Given this list of marker genes NPDC1, HOXA10 (homeobox A10, NCBI Gene Id 3206), RPL38, KCND2, ARTN, C3orf20, ELN, SCN3A, GPR156 (NCBI Gene Id 165829), CSMD3, WWC1, GRN, DENND2C, SERBP1, PYM1, SLCO3A1, FIS1, PTMA, PITPNM1, RPP25L, LETMD1, POU2F3, TOMM40L, SORCS2, COL11A1, MIR646HG, ADGRB2, ACBD4, CXCL12, MB, RERG, SEC31B, BCL6B, TTI1, LRP1, DAPK2, GRK5, INKA1, CHRM1, PIK3R1, KPNA6, ARL8B, MED13, PCDH12, GAS7, CNTNAP1, PCGF1, RPRD1B, EXOSC2, USH1G, SSH2, DLX2, SMAD7, PLXNA2, OPCML, ARMC12, LRCH1, CADPS, TMEM51, LINC00518, NXN, SOX10, EXT2, CA14, CORIN, ARF1 (NCBI Gene Id 375), IL6, SRCIN1, C11orf52, GPR37L1, SLIT3, YY1, CIAO1, STK32B, ESR2, UPK2, KAZALD1, CDC20B, MMP1, RPS4X, NUFIP2, CCNB1IP1, THBS3, TSC22D3, GFI1B, TYSND1, OTOP2, ZNF366, DGKA, CSF3, TMEM127 (transmembrane protein 127), C1QBP, CABP1, MTX1, FLT3LG, AQP6, RPLP0, GRPR, SOST, PUM2, SLC26A10P, NOP10, ANKS6, STAG1, ADORA1, SLC35E4, TMEM51-AS1, ARMCX6, C3orf49, MDK, RORA, FBXO16, TMEM31, FAM177B, ANKRD2, CCR10, ALK, GAD1, LINC02724 (long intergenic non-protein coding RNA 2724), VSTM2L, here is a description of the gene set: Comprehensive identification of all functional elements encoded in the human genome is a fundamental need in biomedical research. Here, we present a comparative analysis of the human, mouse, rat and dog genomes to create a systematic catalogue of common regulatory motifs in promoters and 3' untranslated regions (3' UTRs). The promoter analysis yields 174 candidate motifs, including most previously known transcription-factor binding sites and 105 new motifs. The 3'-UTR analysis yields 106 motifs likely to be involved in post-transcriptional regulation. Nearly one-half are associated with microRNAs (miRNAs), leading to the discovery of many new miRNA genes and their likely target genes. Our results suggest that previous estimates of the number of human miRNA genes were low, and that miRNAs regulate at least 20% of human genes. The overall results provide a systematic view of gene regulation in the human, which will be refined as additional mammalian genomes become available. Human Gene Set: CCANNAGRKGGC_UNKNOWN from publication Xie X, Lu J, Kulbokas EJ, Golub TR, Mootha V, Lindblad-Toh K, Lander ES, Kellis M (PMID 15735639) Genes having at least one occurrence of the highly conserved motif M45 CCANNAGRKGGC in the regions spanning 4 kb centered on their transcription starting sites. The motif does not match any known transcription factor binding site. species: Homo sapiens